The following is a description of a gene set: Cluster A: genes up-regulated in primary lung tumors driven by KRAS activation and loss of STK11; also up-regulated in human squamous cell carcinoma (SCC) vs adenocarcinoma subtype of NSCLC (non-small cell lung cancer). from publication Ji H, Ramsey MR, Hayes DN, Fan C, McNamara K, Kozlowski P, Torrice C, Wu MC, Shimamura T, Perera SA, Liang MC, Cai D, Naumov GN, Bao L, Contreras CM, Li D, Chen L, Krishnamurthy J, Koivunen J, Chirieac LR, Padera RF, Bronson RT, Lindeman NI, Christiani DC, Lin X, Shapiro GI, Jänne PA, Johnson BE, Meyerson M, Kwiatkowski DJ, Castrillon DH, Bardeesy N, Sharpless NE, Wong KK (PMID 17676035) Germline mutation in serine/threonine kinase 11 (STK11, also called LKB1) results in Peutz-Jeghers syndrome, characterized by intestinal hamartomas and increased incidence of epithelial cancers. Although uncommon in most sporadic cancers, inactivating somatic mutations of LKB1 have been reported in primary human lung adenocarcinomas and derivative cell lines. Here we used a somatically activatable mutant Kras-driven model of mouse lung cancer to compare the role of Lkb1 to other tumour suppressors in lung cancer. Although Kras mutation cooperated with loss of p53 or Ink4a/Arf (also known as Cdkn2a) in this system, the strongest cooperation was seen with homozygous inactivation of Lkb1. Lkb1-deficient tumours demonstrated shorter latency, an expanded histological spectrum (adeno-, squamous and large-cell carcinoma) and more frequent metastasis compared to tumours lacking p53 or Ink4a/Arf. Pulmonary tumorigenesis was also accelerated by hemizygous inactivation of Lkb1. Consistent with these findings, inactivation of LKB1 was found in 34% and 19% of 144 analysed human lung adenocarcinomas and squamous cell carcinomas, respectively. Expression profiling in human lung cancer cell lines and mouse lung tumours identified a variety of metastasis-promoting genes, such as NEDD9, VEGFC and CD24, as targets of LKB1 repression in lung cancer. These studies establish LKB1 as a critical barrier to pulmonary tumorigenesis, controlling initiation, differentiation and metastasis. studied in species Mus musculus Human Gene Set: JI_CARCINOGENESIS_BY_KRAS_AND_STK11_UP, and this is the list of marker genes: TP63, ADAM8, COL17A1, TIAM1, KRT6B, GPR87, KRT5, LYPD3 (NCBI Gene Id 94931), TFAP2A, BNC1, PKP1, PPBP